The following is a description of a gene set: Human Gene Set: MIR4778_3P Genes predicted to be targets of miRBase v22 microRNA hsa-miR-4778-3p in miRDB v6.0 with MirTarget v4 prediction scores > 80 (high confidence targets). from publication Chen Y, Wang X (PMID 31504780) species: Homo sapiens, and this is the list of marker genes: SMIM43, ULBP1, SOCS7, CPEB3, SLC5A7, SPRY4, EBPL, PALMD, APBB2, IGLON5, BRINP1, TRDN, SDR16C5, DKC1, C14orf119, DAZ2, SEPTIN10, PEG10, RBBP5, ATP8B3 (NCBI Gene Id 57203), PCDH19, SAMD8, POLR1D, CDH9, IL36G, CLDN18, USP12, PARP8, NRG1, POTEC, SLITRK6, PLOD2, TAL1, HAVCR2, BCL2L13, BCOR, ZNF547, TMTC3, COX17, C1orf226, FXR1, PSMD1, PAX8, TXNL4B, TFEC, TMED7-TICAM2, EIF3J, ERCC6, PRKACB, BMF, ADRA2A, RTN3, MEGF11, KCNA1, SMAD3, ULK1, C11orf87, RBM47, TM9SF3, CBLN4, KCNMB2, MIEF1, ERC1, DDI2, CD84, MED30, APELA, PURG, FAM168B, PRRG4, NPY2R, MOBP, NCOA1 (nuclear receptor coactivator 1), NIPAL4, FZD1, ZBTB8A, KITLG, ZNF687, ACSM2A, RNF217, CACNA1A (calcium voltage-gated channel subunit alpha1 A), RTKN2, FAM124B, ADD1, DAZ4, ZBTB38, CALHM1, ILRUN (NCBI Gene Id 79138), SLC9B2, ASCC3, ING4, HEPH, RANBP3L, PCYOX1L, CTLA4, MMP8, NFIC, NLRC3, ATP2B2, CA3, CDC73, BSPRY, CDC14A, NEDD9, LRP6, ZCCHC10, ELK4, PGBD5, WDFY3, TMTC1, AAK1, TMPRSS11E, BCL2L14, NHS, MED21, EPHB1, PLXNA1, PLPPR4, LZTFL1, PCDH15, SATB2, PAPPA2, ARID5A, ERBIN, PINX1 (NCBI Gene Id 91819), MED19, CLDN8, TAF8, ATP5IF1, TEX11, DNM3, MTFR1L, SBSPON, CPD, GDNF, ANKRD17, SAMD4A, DDB1, ATF3, GANAB, GLUD2, PMS1, RHOU, C19orf33, PRPF4, PROP1, USP13, SEC61B, NTRK2, HBEGF, STON1-GTF2A1L, EFCAB14, TENM1 (NCBI Gene Id 10405), ELAVL4, CNNM2, NETO1, PIP5K1A (phosphatidylinositol-4-phosphate 5-kinase type 1 alpha), FAM9B, SEMA4D, PLEKHA8, CERS6, ZNF704, SRP19, LDHA, MAP4K4, PLAC8, HSCB, MS4A14, PTPRD, IGDCC3, GOLGA4, CDK6, SRSF8, ARL13B, TBC1D7, CYP2U1, HOXC8, RILPL1, XIRP1, CD55, GALNT13, LILRB2, C1orf21, FBXO45 (F-box protein 45), DSC2, PCNX1, ENSA, NSUN7, SCNN1G (sodium channel epithelial 1 subunit gamma), RTL5, HIF1A, MROH9, FAM78A, BDP1, TATDN3, ENDOU, MEF2C (myocyte enhancer factor 2C), CUL4A, NBPF20, MYOCD, DLG1, ARCN1, ZCCHC17, ARL17A, PCDH17, ABHD17C, ZNF107, RUNX1T1, COL6A3, CCL16, BCCIP, SPTBN1, SH3TC2, CYSLTR1, BPTF, BMPER, RNF214, ZNF555, RNF19B, AMACR, CDKL1, RBMS3, MS4A8, MCM9, BAALC, TM2D3, CCDC110, UBE2F, ITPR2, LGSN, DCAF7, SLC4A4, ELAPOR2, TSPAN5, CLVS2, NR4A1, TMEM39A, ASCL1, ATF7IP2, DDHD1, LYRM1, DELE1, ZSCAN5A, ZSWIM7, CELF4, CDC42SE2, SPRED1, RIT2, PRX, SEC22A, DYNC2LI1, AXIN2, GCA, CFTR